The following is a description of a gene set: from publication Wierenga AT, Vellenga E, Schuringa JJ (PMID 18779318) Proteins identified in complex with PML in K562 cells (lymphoblast). species: Homo sapiens The level of transcription factor activity critically regulates cell fate decisions, such as hematopoietic stem cell (HSC) self-renewal and differentiation. We introduced STAT5A transcriptional activity into human HSCs/progenitor cells in a dose-dependent manner by overexpression of a tamoxifen-inducible STAT5A(1*6)-estrogen receptor fusion protein. Induction of STAT5A activity in CD34(+) cells resulted in impaired myelopoiesis and induction of erythropoiesis, which was most pronounced at the highest STAT5A transactivation levels. In contrast, intermediate STAT5A activity levels resulted in the most pronounced proliferative advantage of CD34(+) cells. This coincided with increased cobblestone area-forming cell and long-term-culture-initiating cell frequencies, which were predominantly elevated at intermediate STAT5A activity levels but not at high STAT5A levels. Self-renewal of progenitors was addressed by serial replating of CFU, and only progenitors containing intermediate STAT5A activity levels contained self-renewal capacity. By extensive gene expression profiling we could identify gene expression patterns of STAT5 target genes that predominantly associated with a self-renewal and long-term expansion phenotype versus those that identified a predominant differentiation phenotype. Human Gene Set: WIERENGA_PML_INTERACTOME, and this is the list of marker genes: ARF4, PLEC, CLPX (caseinolytic mitochondrial matrix peptidase chaperone subunit X), HNRNPF, ALB, PRKCB, KPNB1, TUBA1A (NCBI Gene Id 95407), DUOX1, MCM7, CAD, STK38, OAT, EEF1A1, ZYX, POLDIP2, NUP93, RPS27, ACTG1, ABCE1, PPM1B, EMD, EEF1G, RPS18, FER1L6, GCN1, PRKDC, RPS3, CALU, CTPS1, PLCB4, KARS1, RPN1, AHSG, DNAH5, RPL3, YTHDF2, HSPA5, TUBB3, KAT6B (NCBI Gene Id 23522), ABCF2, ATP5F1C